Given this list of marker genes Secisbp2, Pstk, Eif4a3, Eefsec, Eif4a3l1, Trnau1ap, Sars1, Eif4a3l2, Sepsecs, here is a description of the gene set: studied in species Mus musculus The continuation of translation beyond a stop codon by the use of a special tRNA that recognizes the UAG and UGA codons as modified amino acids, rather than as termination codons. Mouse Gene Set: GOBP_TRANSLATIONAL_READTHROUGH